Given this list of marker genes Bcl3 (B cell leukemia/lymphoma 3), Notch2, Mfng, Tnfaip3, Ptk2b (PTK2 protein tyrosine kinase 2 beta), Cdh17, Dock10, Dock11, Dll1, Lfng, here is a description of the gene set: The process in which a B cell in the spleen acquires the specialized features of a marginal zone B cell. Marginal zone B cells are localized in a distinct anatomical region of the spleen that represents the major antigen-filtering and scavenging area (by specialized macrophages resident there). It appears that they are preselected to express a BCR repertoire similar to B-1 B cells, biased toward bacterial cell wall constituents and senescent self-components (such as oxidized LDL). Mouse Gene Set: GOBP_MARGINAL_ZONE_B_CELL_DIFFERENTIATION species: Mus musculus